The following is a description of a gene set: studied in species Homo sapiens Any process that modulates the frequency, rate or extent of protein monoubiquitination. Human Gene Set: GOBP_REGULATION_OF_PROTEIN_MONOUBIQUITINATION, and this is the list of marker genes: FANCM, BIRC2, UBB, PEF1, WDR48, PDCD6